The following is a description of a gene set: Genes up-regulated in comparison of dendritic cells (DC) stimulated with LPS (TLR4 agonist) at 2 h versus DC cells stimulated with CpG DNA (TLR9 agonist) at 2 h. from publication Amit I, Garber M, Chevrier N, Leite AP, Donner Y, Eisenhaure T, Guttman M, Grenier JK, Li W, Zuk O, Schubert LA, Birditt B, Shay T, Goren A, Zhang X, Smith Z, Deering R, McDonald RC, Cabili M, Bernstein BE, Rinn JL, Meissner A, Root DE, Hacohen N, Regev A (PMID 19729616) studied in species Homo sapiens mouse primary BMDCs were stimulated with tlr ligands and gene expression changes were profiled on Affymetrix arrays Human Gene Set: GSE17721_LPS_VS_CPG_2H_BMDC_UP, and this is the list of marker genes: TRIM13, TSC22D1, POLB, DNTTIP1, PEAK1, HACD4, BRD2, RND3, KIF1B, GRIK5, TUBGCP3, CEP55, PTGER2, ECHDC1, TLL2, NAPA, TTLL1, AURKAIP1, ZNF347, GIMAP7, FER (NCBI Gene Id 2241), MCM7, SOAT2, CLDND1, EMID1, MARCHF5, ALS2, EREG, FAM43A, POF1B, NHERF1, UBE2E3, IL2RA, ZFP36, TMEM186, YIPF5, DDX60, POSTN, CALCRL, HS3ST3A1, SIX1, GJA1, RAB3B, LRP4, B3GNT5 (UDP-GlcNAc:betaGal beta-1,3-N-acetylglucosaminyltransferase 5), TRIM21 (NCBI Gene Id 6737), MARCKSL1, AOX1, SMS, ID4, LARP1, METTL25B, MOBP (NCBI Gene Id 4336), E2F1, TRIM34, SEL1L3, TIMP4, PLS3, ASS1 (argininosuccinate synthase 1), MAGOHB, INHBA, TJP2, APBB3 (amyloid beta precursor protein binding family B member 3), RTL8C, CMPK2, PCDH7, TAPBPL, ISG15, SVIL, GSDMA, BTK, GCNT3, CXCL9, ALDH16A1, HBEGF, RGS2, STAMBPL1, EEPD1, DAB2, TRPT1, MIP, SLC25A37, NPM1, PAPOLB, PLK2, ESYT3, FAM53C, ING3, GPR85, LIF, PICK1, ZNFX1, MRPL9, PIAS2, DCAF15, NEDD9 (NCBI Gene Id 4739), LPAR1, MEST, MAT2A, BUB1B, AIF1, SPRY1, NMD3, CD44, LY6H, WNT3A, LYZL4, SDC4, MRPL10, CGGBP1, AP4B1, RAD9B, DCAF5, POLD2, PABPC1, FASLG, GEM, COPS8 (NCBI Gene Id 10920), ERC1, COCH, ADCY7 (NCBI Gene Id 113), HLTF (NCBI Gene Id 6596), PTPRK, KDM5C, POLR2G, SLC12A7, DUSP16, IFRD1, CCNG2, HSPA5 (NCBI Gene Id 3309), FRMD6, ZNF277, TNFRSF11A, MKRN1, CDKN1B, YWHAE, RILPL2, WIZ, TNFSF8, SHPRH, TREX1, STK19, GYPC, RCAN1, REEP1, LCLAT1, GSTM3, ARHGAP10, NFIL3, HCCS, SLC4A8, ACVR2A, UBL7, SMARCC1, KRT33A, RTP4, DENND2D, KBTBD2, TTC4, SNTG2, PPFIA4, PSMB8, MED20, NXF1, TRIM26, BMAL1, DUSP1 (dual specificity phosphatase 1), MPP1, DAGLB, SEC24D, VPS37B, TFAP2C, CD180, MX2, XRCC6, SCARB1, GPRASP1, MAFF, PSAP, PCDHB3, TSPAN13, HILPDA, SERPINI2, TMEM203, FOS, FICD, MX1, CST7, PFDN2, AP3S2, KRTAP19-5, LRRC14, APBB1, FOLR1, PTCH1, NSG1, BRIX1, DNAJB7, MMP13, RASA1